Given this list of marker genes MARK3, KRAS, ITGA2B, CAMK2B, RAP1B, APBB1IP, FGA (NCBI Gene Id 2243), CAMK2D, PHB1, ARRB1, FGG, MAPK1, RAF1, ARAF, CAMK2A, CNKSR2, ARRB2, ITGB3, TLN1, VWF (von Willebrand factor), CNKSR1, BRAP, CALM1, FGB, JAK2, PEBP1, YWHAB, IQGAP1, FN1, SRC, MAPK3, ACTB, ACTG1, CAMK2G, KSR2, BRAF, HRAS, KSR1, MAP2K2, MAP2K1, RAP1A, MAP3K11, CSK, NRAS, VCL, here is a description of the gene set: studied in species Homo sapiens In addition to the highly prevalent and activating V600E BRAF mutations, numerous moderately activating and less common mutations have also been identified in human cancers. Unlike the case for their highly activating counterparts, signaling through these mutant versions of BRAF depends both upon RAS binding and RAF dimerization part of: Oncogenic MAPK signaling Reactome Pathway: Signaling by moderate kinase activity BRAF mutants